The following is a description of a gene set: species: Mus musculus from publication Rampon C, Jiang CH, Dong H, Tang YP, Lockhart DJ, Schultz PG, Tsien JZ, Hu Y (PMID 11070096) Human Gene Set: RAMPON_ENRICHED_LEARNING_ENVIRONMENT_EARLY_DN An enriched environment is known to promote structural changes in the brain and to enhance learning and memory performance in rodents. To better understand the molecular mechanisms underlying these experience-dependent cognitive changes, we have used high-density oligonucleotide microarrays to analyze gene expression in the brain. Expression of a large number of genes changes in response to enrichment training, many of which can be linked to neuronal structure, synaptic plasticity, and transmission. A number of these genes may play important roles in modulating learning and memory capacity. Genes down-regulated in the brain cortex of mice that were exposed to an enriched learning environment for one day., and this is the list of marker genes: BAX, DNAJB6, CIT, PAFAH1B1, SPTBN1, MT3, PREP, RXRA, CASP6, NRGN